The following is a description of a gene set: Genes down-regulated in multiple myeloma (MM) compared to monoclonal gammopathy of uncertain significance (MGUS). from publication Davies FE, Dring AM, Li C, Rawstron AC, Shammas MA, O'Connor SM, Fenton JA, Hideshima T, Chauhan D, Tai IT, Robinson E, Auclair D, Rees K, Gonzalez D, Ashcroft AJ, Dasgupta R, Mitsiades C, Mitsiades N, Chen LB, Wong WH, Munshi NC, Morgan GJ, Anderson KC (PMID 12947006) To define specific pathways important in the multistep transformation process of normal plasma cells (PCs) to monoclonal gammopathy of uncertain significance (MGUS) and multiple myeloma (MM), we have applied microarray analysis to PCs from 5 healthy donors (N), 7 patients with MGUS, and 24 patients with newly diagnosed MM. Unsupervised hierarchical clustering using genes with a large variation across all samples defined 2 groups: N and MGUS/MM. Supervised analysis identified genes differentially expressed between N and MGUS and genes differentially expressed between N and MM, 197 of which were also differentially regulated between N and MGUS. Only genes were differentially expressed between MGUS and MM samples, indicating that the differences between MGUS and MM are smaller than those between N and MM or N and MGUS. Differentially expressed genes included oncogenes/tumor-suppressor genes (LAF4, RB1, and disabled homolog 2), cell-signaling genes (RAS family members, B-cell signaling and NF-kappaB genes), DNA-binding and transcription-factor genes (XBP1, zinc finger proteins, forkhead box, and ring finger proteins), and developmental genes (WNT and SHH pathways). Understanding the molecular pathogenesis of MM by gene expression profiling has demonstrated sequential genetic changes from N to malignant PCs and highlighted important pathways involved in the transformation of MGUS to MM. studied in species Homo sapiens Human Gene Set: DAVIES_MULTIPLE_MYELOMA_VS_MGUS_DN, and this is the list of marker genes: CAP1, MARCKS, ACTN1, GLUL, ARHGAP1, NPC2, DOK1, CD27, CTSG, FCER1G, MYH9, PPBP, VNN2, SLC7A7, DEFA3, LITAF, RNASE6, MERTK, CDK14, S100A8, VCL, LASP1, TLR1, SAT1, TMSB4X, LY96